The following is a description of a gene set: species: Mus musculus Mouse Gene Set: GOBP_POSITIVE_REGULATION_OF_NEUROTRANSMITTER_UPTAKE Any process that activates or increases the frequency, rate or extent of the directed movement of a neurotransmitter into a neuron or glial cell., and this is the list of marker genes: Nat8l, Prkn, Slc17a8, Drd2, Itgb1, Rab3b